The following is a description of a gene set: Any process involved in forming the mature 3' end of a snoRNA molecule linked to prior polyadenylation of the 3'-end of the precursor snoRNA. species: Homo sapiens Human Gene Set: GOBP_POLY_A_DEPENDENT_SNORNA_3_END_PROCESSING, and this is the list of marker genes: TENT4B, EXOSC3, EXOSC10, EXOSC5, EXOSC6, PARN, EXOSC2, EXOSC4